Given this list of marker genes RNF186, RBPJL, PLA2G1B, REG1A, CELA3B (chymotrypsin like elastase 3B), KIRREL2, NOMO1, MT1L, SERPINI2, CTRB1, CTRL, CTRC (NCBI Gene Id 11330), MATN4, SCG5, CCDC110, PLBD1, LMAN2, HEXD, ZC3H18, TPRN, CLPS, TBX6, MSRB1, SYCN, CELA3A (chymotrypsin like elastase 3A), AKR7A3 (NCBI Gene Id 22977), ENSG00000271820, MPV17L, CTRB2, GP2 (NCBI Gene Id 51724, glycoprotein 2), SEL1L, AQP8, SLC16A12, FREM2-AS1, CELP, CPB1, CEL (NCBI Gene Id 1056), POMC, SSR4, REG3G, MID1IP1, PNLIPRP1, GPHA2, CPA2, TMED6, PTF1A, RARRES2, PRSS1 (NCBI Gene Id 5644), DPEP1, LINC01624, SPINK1, DIRAS3, KLK1, CPA1, BTG2, FBXO2, ERP27, DLK1, CELA2A, CUZD1, here is a description of the gene set: studied in species Homo sapiens The gene expression program underlying the specification of human cell types is of fundamental interest. The study authors generated human cell atlases of gene expression and chromatin accessibility in fetal tissues. For gene expression, the study authors applied three-level combinatorial indexing to >110 samples representing 15 organs, ultimately profiling ~4 million single cells. The study authors leveraged the literature and other atlases to identify and annotate hundreds of cell types and subtypes, both within and across tissues. Our analyses focused on organ-specific specializations of broadly distributed cell types (such as blood, endothelial, and epithelial), sites of fetal erythropoiesis (which notably included the adrenal gland), and integration with mouse developmental atlases (such as conserved specification of blood cells). These data represent a rich resource for the exploration of in vivo human gene expression in diverse tissues and cell types. Marker genes curated from the annotated cluster as represented in the Descartes Human Gene Expression During Development database. Human Gene Set: DESCARTES_MAIN_FETAL_ACINAR_CELLS from publication Cao J, O'Day DR, Pliner HA, Kingsley PD, Deng M, Daza RM, Zager MA, Aldinger KA, Blecher-Gonen R, Zhang F, Spielmann M, Palis J, Doherty D, Steemers FJ, Glass IA, Trapnell C, Shendure J (PMID 33184181)